The following is a description of a gene set: Any process that stops, prevents, or reduces the frequency, rate, or extent of interleukin-8 production. studied in species Homo sapiens Human Gene Set: GOBP_NEGATIVE_REGULATION_OF_INTERLEUKIN_8_PRODUCTION, and this is the list of marker genes: PTPN22, MAP2K5, MIR106A, ANXA1, MIR488, MIR920, IL10, ARRB1, SSC5D, MIR302D, MIR129-1, MIR132, MIR181A2, CD33, IL6R, MIR204, MIR520C, MIR106B, MIR203A, MIR98, ELANE, BCL3, MIR146A, MIR506, MAPKBP1, KLF4, MIR520B (NCBI Gene Id 574473), OTUD7B, BPI, MIRLET7C, TLR6, ANXA4, MIR766, MIR100, CACTIN, MIR302C (NCBI Gene Id 442895), MIR93